The following is a description of a gene set: Candidate mammary tumorigenesis genes from the common insertion sites (CIS) of MMTV virus that induced breast tumors in mice. from publication Theodorou V, Kimm MA, Boer M, Wessels L, Theelen W, Jonkers J, Hilkens J (PMID 17468756) Human Gene Set: THEODOROU_MAMMARY_TUMORIGENESIS We performed a high-throughput retroviral insertional mutagenesis screen in mouse mammary tumor virus (MMTV)-induced mammary tumors and identified 33 common insertion sites, of which genes were previously not known to be associated with mammary cancer and 13 had not previously been linked to cancer in general. Although members of the Wnt and fibroblast growth factors (Fgf) families were frequently tagged, our exhaustive screening for MMTV insertion sites uncovered a new repertoire of candidate breast cancer oncogenes. We validated one of these genes, Rspo3, as an oncogene by overexpression in a p53-deficient mammary epithelial cell line. The human orthologs of the candidate oncogenes were frequently deregulated in human breast cancers and associated with several tumor parameters. Computational analysis of all MMTV-tagged genes uncovered specific gene families not previously associated with cancer and showed a significant overrepresentation of protein domains and signaling pathways mainly associated with development and growth factor signaling. Comparison of all tagged genes in MMTV and Moloney murine leukemia virus-induced malignancies showed that both viruses target mostly different genes that act predominantly in distinct pathways. studied in species Mus musculus, and this is the list of marker genes: KLF15, FGF8, FGF4, MAP3K8, GSE1, EGR3, NOTCH4, FGF6, ATP2B1, ASTN2, PDGFRB, DPP10, WNT1, IGF2, PROS1, SFMBT2, AGAP1, TENM1, FOXC2, RREB1 (NCBI Gene Id 6239), WNT3, JMJD1C, LAMB1, FGF3, FGFR2, PTGIS, FGF10, NKD2, RSPO2, ERAS, RSPO3